The following is a description of a gene set: Human Gene Set: HP_MESOAXIAL_FOOT_POLYDACTYLY species: Homo sapiens The presence of a supernumerary toe (not a hallux) involving the third or fourth metatarsal with associated osseous syndactyly. Mesoaxial foot polydactyly, and this is the list of marker genes: TFAP2B, GJA8, MAP3K20, GJA5, GLI3 (NCBI Gene Id 2737), RAB34